The following is a description of a gene set: studied in species Homo sapiens Human Gene Set: WP_WNTBETACATENIN_SIGNALING_AND_ARTD_FAMILY_MEMBERS Wnt/Beta-catenin signaling and ARTD family members, and this is the list of marker genes: DVL1, DVL3, CUL1, TNK1, PARP10, BTRC, CTNNB1, DVL2, SKP1, PLK1, APC, AXIN1, TNK2, RBX1, PARP1